Given this list of marker genes Tas2r130, Pth2r, Tacr2, Hrh2, Oprk1, Rxfp1, Drd2, Htr1f, F2rl3, Npffr2, Grm3, Gprc5a, Gprc5d, Ffar2, Ntsr1, Cxcr2, Cxcr1, Galr2, Adgrg2, Hcrtr1, Tas2r144, Tas2r123, Mc5r, Gpr143, Agtr2, S1pr2, Ltb4r2, Gpr17, Pth1r, P2ry14, Htr1d, Calcr, Ackr2, Lpar2, Kiss1r, Gpr18, Cnr2, Gabbr2, Adgrb2 (adhesion G protein-coupled receptor B2), Agtr1a, C3ar1, Ptgir, Hrh3, Oxtr, Prokr2, Htr2c, Adgrl1, Mc3r, Gcgr, Adgrb1, Npy1r, Ghrhr, F2rl1, Htr6, Gprc6a, Npy6r, Ltb4r1, Sstr2, Hcrtr2, Hcar2, Fpr1, Grm4, Glp2r, P2ry1, Adcyap1r1, Ccr1l1, Cckar, Adra2c, Htr5b, P2ry4, Prlhr, Ednra, Ccr7, Chrm3, Adrb1, Ccr6, Adgrl2, Ptger3, Ptger1, Fzd3, Gpr174, Gpr50, Ffar1, Prokr1, Avpr2, Oxgr1, Chrm4, Trhr, Lpar6, Npy2r, Grm2, Tacr1, Fzd9, P2ry13, Taar1, Ntsr2, Fzd5 (frizzled class receptor 5), Drd5, Tas2r105, Grm1, Tshr, Tas2r126, Ccr1, Adora3, Hrh4, Tacr3, Tas2r137, Htr1a, Crhr2, Tbxa2r (NCBI Gene Id 21390), Tas2r119, Gper1, Ackr3, Ffar3, Celsr1, Tas2r108, Drd3, Cxcr3, Ackr1 (atypical chemokine receptor 1 (Duffy blood group)), Htr1b, Oprm1 (opioid receptor, mu 1), Gpr68, Lpar4, Celsr3, Sucnr1, Ccr8, Adrb3, Adra1b, Tas2r118, Gpr119, Gpr132, Ptafr, Gpr65, Opn3, Tas2r140, P2ry10, S1pr1, Bdkrb1, Htr5a, Npy5r, Fshr, Npbwr1, Ghsr, Tas2r110, Lpar3, Adra1a, Grm7, Adra2a, Adgre1, Adgre4 (NCBI Gene Id 52614), Fzd8, Mrgprd, Tas2r103 (taste receptor, type 2, member 103), Npsr1, Celsr2, Ffar4, Xcr1, Ptgdr, Ccr10, S1pr3, Adora1, Htr4, Gpbar1, Adgre5, Cxcr5, Gpr6 (G protein-coupled receptor 6), Fzd1, Rxfp4, Cysltr1, Ptgfr, Ednrb, P2ry6, Cysltr2, Nmur2, S1pr5, Mtnr1a, Ccrl2, Glp1r, Gipr, Adora2b, Htr2b, Adgrl4, Nmur1, Drd1 (dopamine receptor D1), Mtnr1b, Grm6, Oprd1, Sstr1, Agtr1b, Crhr1, Gpr15, Lpar5, Adgrl3, Rgr, Chrm1, Aplnr, P2ry2, Grm5, Fzd7, Ccr9, Drd4, Galr1, Rxfp2, Lpar1, Rrh, Cnr1, Grpr, Avpr1b, Avpr1a, Fzd4, Hrh1, Ptger4, Uts2r (urotensin 2 receptor), Grm8, Smo, Ptger2, Ccr2, F2rl2, Sstr5, Opn5, Tas2r121, Cckbr, Chrm5, Sctr, Opn4, Npy4r, Mchr1, Htr7 (5-hydroxytryptamine (serotonin) receptor 7), Casr, Rxfp3, Nmbr (NCBI Gene Id 69412), Gnrhr, Cxcr6, Ccr3, Bdkrb2, Chrm2, Gabbr1, Qrfpr, Adora2a, C5ar1, C5ar2, Adrb2, Mc2r, Adra2b, Cxcr4, Sstr4, Vipr2, Adgrg1, S1pr4, Fzd6, Adgrb3, Calcrl, Cx3cr1 (NCBI Gene Id 13051), F2r, Lhcgr, Mc4r, Tmigd3, Vipr1, Fzd2, Ccr4 (NCBI Gene Id 12773), Sstr3, Mas1, Adra1d, P2ry12, Mc1r, Gprc5b, here is a description of the gene set: studied in species Mus musculus GPCRs, non-odorant Mouse Gene Set: WP_GPCRS_NONODORANT